Given this list of marker genes POLR3E, POLR1C, POLR3F, CRCP, NFIX, POLR2K, NFIB, POLR3B, POLR2L, SSB, NFIA, NFIC, POLR3D, POLR1D, POLR3GL, POLR2H, POLR3H, POLR2E, POLR3C, POLR3G, POLR3A, POLR3K, POLR2F, here is a description of the gene set: Reactome Pathway: RNA Polymerase III Transcription Termination studied in species Homo sapiens part of: RNA Polymerase III Transcription At the end of the cycle, the elongation complex (EC) must be destabilized to release its transcript and DNA. Analogous to initiation, cis-signals and protein factors are required to mediate EC destabilization and release of the transcript from the grip of the RNA polymerase (RNAP). RNAP III achieves efficient termination despite the apparent simplicity of its cis-acting DNA terminator element, a stretch of five or more T residues on the non-template (NT) strand, which directs termination within this site without need for additional cis-elements or trans-acting factors.